Given this list of marker genes RIGI, BTBD2, PLSCR1, PDE6D, BAG1, SOBP (sine oculis binding protein homolog), IRF7, MT2A, CNP, PGAP1, CASP10, MRPL42, MKRN1, FKBP11, IFIT1, TNK2, EIF5A, MMADHC, SLC37A1, LAMP3, KCNA3, IFI16 (interferon gamma inducible protein 16), HLA-G, STAT2, OASL, ZCCHC2, PSMB8, CHSY1, DRAP1, IFIT5, LGALS9, RNF31, LSM1, UBE2Q1, PPP2R2A, MT1G, IFI6, MAD2L1BP, ADAR, PSMA5, CALCOCO2, IFIT2, PSMD7, MT1X, TDRD7, LAP3 (leucine aminopeptidase 3), GSTK1, UBA7, EIF4A2, SLC25A28, NR1H2, SAT1, CMTR1, IFIT3, MT1HL1, ATF4, MKLN1, MCL1, KPNB1, KCNK15-AS1, TRIM14, MT1F, EIF2AK2, CHMP5, FAM186A, NDUFV2, ERGIC2, JADE2, RBCK1, APOL1, TRAK2, IFITM1, MX2, MYD88, SMCHD1, RTP4, USP18, YEATS2, ECE1, RGS7, OAS3, SAMD9, IFITM3, IFIH1, DDX60, TENT5A, MYL12A, N4BP1, DAG1, DNAJA1, TRAFD1, UBE2D3, XAF1, ASH2L, MAIP1, HMGN2, MICB, NMI, C6orf62, IFI44, PSME1, RAB8A, ZNF410, PTMA, PARP12, P3H2, ANKFY1, SP100, MORC3, GTPBP2, BST2, NFYA, FNDC3A, TRIM21, NAPA, SNX6, IFI44L, PPCDC, GNG5, DHX58, TRIM5, TRIM22, TMEM140 (transmembrane protein 140), OAS2, ISG20, USP15, TMEM126B, PARP4, NSD3, MX1, IFITM2, IFI35, TRANK1, CD164, ZBP1, GPR176, BTN3A3, CNDP2, MAGOHB, IARS1, SP110, ATG3, TMEM62, LY6E, MT1H, TRMT5, PRKD2, CCDC85B, PHF11, UBC, MRPL13, IGKV3-20, LPIN2, TAF1D, PSMD11, LRP4, FCHSD2, RNF34, USP25, APOL6, PML, NELFE, PARP11 (poly(ADP-ribose) polymerase family member 11), UBE2L6, DCP1A (decapping mRNA 1A), RSAD2, IRF9, HERC6, RNF25, LGALS3BP, BRD7, GSDMD, PSME2, TRIM26, OAS1, SPATS2L, SRBD1, TMEM187, SHFL (shiftless antiviral inhibitor of ribosomal frameshifting), TRIM62, ELF1, TXNL4B, GBP1, ISG15, HERC5, SPATA6, DGLUCY, HMGN1, HLA-E, TMSB10, CLEC2D, MTHFD2L, CEACAM1, PRRG4, TREX1, CD2AP, EHD4, MID1IP1, GTPBP1, OSBPL1A, here is a description of the gene set: from publication Marigo I, Bosio E, Solito S, Mesa C, Fernandez A, Dolcetti L, Ugel S, Sonda N, Bicciato S, Falisi E, Calabrese F, Basso G, Zanovello P, Cozzi E, Mandruzzato S, Bronte V (PMID 20605485) Genes down-regulated in CD11b+ cells from spleen of healthy C57BL6 mice versus CD11b+ cells from tumor infiltrating monocytes of BALB/c mice bearing 4T1 mammary carcinoma. Tumor growth is associated with a profound alteration of myelopoiesis, leading to recruitment of immunosuppressive cells known as myeloid-derived suppressor cells (MDSCs). Analyzing the cytokines affecting myelo-monocytic differentiation produced by various experimental tumors, we found that GM-CSF, G-CSF, and IL-6 allowed a rapid generation of MDSCs from precursors present in mouse and human bone marrow (BM). BM-MDSCs induced by GM-CSF+IL-6 possessed the highest tolerogenic activity, as revealed by the ability to impair the priming of IFN- -producing CD8+ T cells upon in vivo adoptive transfer. Moreover, adoptive transfer of syngeneic, GM-CSF+IL-6-conditioned MDSCs to diabetic mice transplanted with allogeneic pancreatic islets resulted in long term acceptance of the allograft and correction of the diabetic status. Cytokines inducing MDSCs acted on a common molecular pathway. Immunoregulatory activity of both tumor-induced and BM-derived MDSCs was entirely dependent on C/EBP transcription factor, a key component of the emergency myelopoiesis triggered by stress and inflammation. Adoptive transfer of tumor antigen-specific CD8+ T lymphocytes resulted in therapy of established tumors only in mice lacking C/EBP in myeloid compartment. These data unveil another link between inflammation and cancer and identify a novel molecular target to control tumor-induced immune suppression. We used gene expression analysis to identify those factors, secreted by tumor-infiltrating MDSC, which could drive emathopoiesis. Moreover we compare gene expression profile of tumor-induced MDSC, obtained from either the spleen and the tumor infiltrate of tumor bearing mice, and in vitro bone marrow-derived MDSC. studied in species Homo sapiens Human Gene Set: GSE21927_SPLEEN_C57BL6_VS_4T1_TUMOR_BALBC_MONOCYTES_DN